The following is a description of a gene set: Avascular necrosis of the proximal epiphysis of the femur occurring in growing children and caused by an interruption of the blood supply to the head of the femur close to the hip joint. The necrosis is characteristically associated with flattening of the femoral head, for which reason the term coxa plana has been used to refer to this feature in the medical literature. Avascular necrosis of the capital femoral epiphysis species: Homo sapiens Human Gene Set: HP_AVASCULAR_NECROSIS_OF_THE_CAPITAL_FEMORAL_EPIPHYSIS, and this is the list of marker genes: RAB3GAP2, ADAMTS2, COL2A1, ATP7A, COL1A2, RAD21, EXT1, DVL3, TREX1, UNC45A, CREBBP, TRPS1, COMP, ADAMTSL2, FN1, UFSP2, EP300, TRPV4, COL1A1, FZD2, DVL1, NEK9, SIL1, TINF2, SKIC3, SRCAP, TONSL, SLC2A10, WNT5A, MATN3